Given this list of marker genes MORF4L1, CTSS, LPP, GGA2, HLA-DRB1, APOE, CTSH, RASA3, PXK, CD74, HLA-DQA2, IFNGR1, IL10RB (NCBI Gene Id 3588), CXCR5, GNPNAT1, NEAT1, JAK2, TBC1D14, PTPRC, ABCA1, POU6F1, ADCY7, TMOD3, IL10RA, BARX1, HLA-DMB, ADD1, DGCR6, IGKV5-2, SDF2, MAN1A1, ID3, MACF1, CD83, CNOT6L, MS4A1, MCL1, HLA-DOB, VPS28, MAP2K1, FAM76B, SH3BP2, RIPOR2, CR2, LAT2, C12orf57, MEF2C, PISD, RGS14, ARHGEF3, FCER2, CMTM6, B4GALNT1, WDR43, CRYBG1, C19orf48P, RAB8A, BGLAP, YTHDC1, SAMHD1, OSBPL5 (oxysterol binding protein like 5), EEIG1, PHTF2, PIP4K2A, SELL, HLA-DMA, HLA-DOA, RMI1, PEA15, MYCBP2, IGKV1D-43, MAP3K8 (mitogen-activated protein kinase kinase kinase 8), RAP1GDS1 (Rap1 GTPase-GDP dissociation stimulator 1), ZFP36L1, PTPN6, MFSD14B, ETS1, NCF4, SORL1, FOXD4, ADRB2, PPM1M (protein phosphatase, Mg2+/Mn2+ dependent 1M), SLC4A7, CERS2, SCD, CER1, SMAP2, LCP1, IL2RG, IGHD, IRF8, EBI3, GPR65, SGPP1, here is a description of the gene set: Human Gene Set: MORI_MATURE_B_LYMPHOCYTE_UP Up-regulated genes in the B lymphocyte developmental signature, based on expression profiling of lymphomas from the Emu-myc transgenic mice: the mature B studied in species Mus musculus The Emu-myc transgenic mouse has provided a valuable model for the study of B-cell lymphoma. Making use of gene expression analysis and, in particular, expression signatures of cell signaling pathway activation, we now show that several forms of B lymphoma can be identified in the Emu-myc mice associated with time of tumor onset. Furthermore, one form of Emu-myc tumor with pre-B character is shown to resemble human Burkitt lymphoma, whereas others exhibit more differentiated B-cell characteristics and show similarity with human diffuse large B-cell lymphoma in the pattern of gene expression, as well as oncogenic pathway activation. Importantly, we show that signatures of oncogenic pathway activity provide further dissection of the spectrum of diffuse large B-cell lymphoma, identifying a subset of patients who have very poor prognosis and could benefit from more aggressive or novel therapeutic strategies. Taken together, these studies provide insight into the complexity of the oncogenic process and a novel strategy for dissecting the heterogeneity of B lymphoma. from publication Mori S, Rempel RE, Chang JT, Yao G, Lagoo AS, Potti A, Bild A, Nevins JR (PMID 18922927)